Given this list of marker genes FGF2 (fibroblast growth factor 2), MYOM2, FHL1, SGCG, FXYD1 (NCBI Gene Id 5348), EDNRA, RYR1, NOS1, ALDOA, MYOM1, PLN, CALD1, NEB, HRC, TNNI2, COL6A3, SSPN, MYL1, ACTA1, MYH7, ADAM12, TCL1A, PPP1R12B, TNNT3, BDKRB2, VIPR1, CRYAB, ACTG2, FLII, CASQ2, CKMT2, CHRNB1, MYH3, ACTC1, MYH11, ACTA2 (NCBI Gene Id 59), GJA5, here is a description of the gene set: studied in species Homo sapiens Muscle genes. Human Gene Set: MODULE_512